The following is a description of a gene set: Mouse Gene Set: GOBP_ISOPRENOID_METABOLIC_PROCESS The chemical reactions and pathways involving isoprenoid compounds, isoprene (2-methylbuta-1,3-diene) or compounds containing or derived from linked isoprene (3-methyl-2-butenylene) residues. studied in species Mus musculus, and this is the list of marker genes: Rdh19, Rdh5, Hmgcs1, Crppa, Cyp2w1, Mvd, Dgat1, Adh6b, Adh5, Cyp2j6, Amacr (alpha-methylacyl-CoA racemase), Nus1, Clps, Idi2, Cyp26c1, Lcn5, Cyp1a1, Retsat, Cyp1a2, Star, Htra2, Adh7, Dgat2, Cyp2e1, Hmgcs2, Rpe65, Srd5a3, Isx, Rdh8, Bco2, Rarres2, Rdh16, Lrat, Cyp26b1, Rbp4, Aldh3a2, Rbp1, Plb1, Rdh9, Rdh12, Dpm2, Th, Fdft1, Akr1c18, Cyp3a11 (NCBI Gene Id 13112), Hmgcr, Ces2a, Ces1d, Rdh1, Adh6a, Ces1f, Rbp2, Dpagt1, Cyp2s1, Egfr, Cyp3a41b, Awat2, Rdh11, Dhrs4, Fdps, Lss, Lipe, Rdh14, Pdss2, Dhrs3, Ggps1, Dhdds, Idi2l, Aldh1a2, Akr1b1, Bco1, Idi1-ps1, Aldh1a1, Ldlr, Pdss1, Rdh13, Dhrs7, Rdh10, Ces2c, Pnpla2, Sp1, Dpm3, Coq2, Cyp3a16, Aldh8a1, Rdh7, Cyp3a44, ENSMUSG00000144291, Cyp3a41a, Phyh, Lipa, Pex5, Klf9, Crabp2, Cyp26a1, Lpl, Pmvk, Prmt3, Pecr, Rdh16f2, Idi1 (isopentenyl-diphosphate delta isomerase), Plpp6, Adh4, Ces2e, Dhrs9, Dolk, Adh1, Aldh1a7, Aldh1a3, Abca4, Mvk, Sdr9c7, Dpm1, Hsd17b6, Cyp2c55, Crh, Pnlip, Sdr16c5, Cyp1b1, Ttr, Ces1e, Strap